Given this list of marker genes Cltb, Rassf9, Aftph, Ap1b1, Furin, Ap1s3, Ap1m2, Cltc, Ap1s2, Clta, Ap1s1, Ap1m1, Ap1g1, Clba1, Ap1g2, Nrgn, Ap4b1, Slc18a3, Synrg, here is a description of the gene set: The lipid bilayer surrounding a vesicle transporting substances between the trans-Golgi network and other parts of the cell. Mouse Gene Set: GOCC_TRANS_GOLGI_NETWORK_TRANSPORT_VESICLE_MEMBRANE species: Mus musculus